The following is a description of a gene set: A SWI/SNF-type complex that contains 8 to 14 proteins, including both conserved (core) and nonconserved components; contains the ATPase product of the yeast SNF2 or mammalian SMARCA4/BAF190A/BRG1 gene, or an ortholog thereof. Human Gene Set: GOCC_SWI_SNF_COMPLEX species: Homo sapiens, and this is the list of marker genes: DPF3, ACTL6A, BCL7C, ACTB, BRD9, DPF2, SS18, BICRA, SMARCD3, SMARCE1, SMARCA4, ARID1A, ARID1B, ACTL6B, BCL11B, NCR1, SMARCB1, BCL7B, PBRM1, SMARCA2, PHF10, SMARCD1, RB1, BCL11A, BCL7A, SMARCC2, BICRAL, SMARCD2, ARID2, SMARCC1 (SWI/SNF related, matrix associated, actin dependent regulator of chromatin subfamily c member 1)